Given this list of marker genes NUDT12, ENPP5, CILP2, NUDT13, NUDT6, NUDT17, ENPP1, CILP, here is a description of the gene set: Catalysis of the reaction: a dinucleotide + H2O = 2 mononucleotides. species: Homo sapiens Human Gene Set: GOMF_DINUCLEOTIDE_PHOSPHATASE_ACTIVITY